Given this list of marker genes DISP1, FKRP, ASS1, TCF21, WT1, BASP1, MSC, FGFRL1, STRA6 (signaling receptor and transporter of retinol STRA6), here is a description of the gene set: The progression of the diaphragm over time from its initial formation to the mature structure. The diaphragm is a skeletal muscle that is responsible for contraction and expansion of the lungs. studied in species Homo sapiens Human Gene Set: GOBP_DIAPHRAGM_DEVELOPMENT